Given this list of marker genes NEK1, MIA3, FGFR3, IHH, EVC, SALL1, KIF15, MATN3, POR, NKX3-2, PDE4D, SLC26A2, COL9A1, COL9A2, CPLX1, ERCC6, IFIH1, RPS6KA3, EXT1, IFT52, FLNB, BPNT2, KCNH1, RAD21, LETM1, BMPR1B, EIF2AK3, FGFRL1, TRAPPC2, RMRP (RNA component of mitochondrial RNA processing endoribonuclease), IFT140, GNPAT, NPR2, MGP, GPX4, PCNT (pericentrin), MIR140, CTBP1, RAB23, COL2A1, MRPS28, TRIP11, NSD2, PRKAR1A, FLNA, COG4, IFT172, EVC2, BGN, SRCAP, TRPV4, COL9A3, ARSL, DYM, TRPS1, COMP, ATR, RUNX2, NPR3, ERI1, GDF5, TONSL, ERCC8, here is a description of the gene set: studied in species Homo sapiens Abnormal upper limb epiphysis morphology Human Gene Set: HP_ABNORMAL_UPPER_LIMB_EPIPHYSIS_MORPHOLOGY